Given this list of marker genes ZNF253, MED14, HIVEP3, ZNF620, SMURF2, TAF6, SUMO1, ZNF577, RAD50, SETD1B, RBL2, MLST8, ZNF625, SOX2, RFFL, ZNF324, TJP1, CNOT11, ARID3A, ZNF222, CDK6, DGCR8, RORA, ZNF479, USP7, G6PC1, MAPK3, MRE11, MED26, ZNF528, CDK13, COX7A2, ZNF496, H3-3A, NBN, TRPC3, ASH2L, ZNF140, PRKAG1, KLF4, MYBL2, ZIM2, PAX5, ZNF671, WRN, JUN, H19, NR4A2, THBS1, CDK5R1, ZNF439, ZNF233, TCF7, FOXP3, NFYA, KCTD15, TCF7L2, SCMH1, CDC27, PIN1 (NCBI Gene Id 5300), GATA3, APOE, PSMD11, ZNF875 (NCBI Gene Id 3102), PIDD1, BBC3, PSMD7, MED25, CDK5, MED20, RORB, ZNF614, ZNF429, ZFP69, ZNF77, ING2, H2BC1, ZNF746, PSMB7, SMARCC2, SREBF1, BCL6, PHC2, IQSEC3, COX4I2, ZNF621, ZNF860, CNOT2, ZNF703, H3C15 (NCBI Gene Id 449003), TAF4, ZNF471, ZNF665, BRD7, ZNF840P, ZNF561, MIR132, ZKSCAN8, ZKSCAN7, MTOR, SKP2, TXNRD1 (NCBI Gene Id 7296), ZNF767P, PSMB4, ZNF485, AURKB, KRABD4, SMARCD3, ZNF589, MAML2, GLI2, TGIF1, ZNF692, MIR302B, PPP2R5C, NR2E1, TFAP2B, ZNF670, SP1, NLRC4, ZNF92, COL1A2, SMARCD2, KMT2A, ZNF544, RETN, PF4, CCNK, POLR2H, CHM, CTSK, ZNF717, MAP2K6, PSMC6, ZNF394, PIP4P1, PPM1D, RMI2, SUPT4H1, ZNF221, SP7, CTDP1, TAF10, NR2F6, ZKSCAN4, RPA3, SMARCA4, ZNF555, FOS, YWHAZ, ZNF702P, NR5A2, PSMC1, HNF4G, BRPF3, CCNT2, E2F4, EHMT1, ZNF569, BRCA1, MOV10, DAXX, TAF7L, ZFP90, ZNF529, PCGF2, NR1I2, NCOR1, RAD17, EP300, RAD1, PTEN, POLR2G, UBE2E1, CLDN5, PSMC5, WWTR1, AGO1, TP53AIP1, MT-CO2, ZNF75A, CCNH, PHF20, MIR17, ZNF549, ZNF677, BLK, DDIT3, RPA2, COX7A2L, NR4A1, PSMD6, SPI1, PSMA6, ERCC2, COX6A1, ZFP30 (ZFP30 zinc finger protein), RBBP7, ZNF667, ZNF585B, RBFOX1, WWP1 (NCBI Gene Id 81891), ZNF714, ZNF793, ZNF18, KMT2D, ZFP2, COX6C, CHEK2, ZNF721, ZNF792, ITGA5, CTNNB1, CTLA4, PTPN4, KRABD5, ZNF764, SGK1, H2AC4 (H2A clustered histone 4), NOTCH1, RXRG, SKI, ZNF302, ZNF552, NR3C1 (nuclear receptor subfamily 3 group C member 1), COX5B (cytochrome c oxidase subunit 5B), RARG, PRKAA2, USP9X, ZNF704, TAL1, ZNF235, TFAP2E, SLC2A3, ZNF268, ZNF706, DDIT4, MAPKAPK5, ZNF510, KAT5, AKT3, MED4, IGFBP1, ZNF202, ANAPC5, YWHAG, ZNF100, ZNF334, RGCC, COX8C, SOX9, NELFCD, RBBP4, MIR675, SPP1, PINK1, PCGF5, YWHAH (tyrosine 3-monooxygenase/tryptophan 5-monooxygenase activation protein eta), PRKACA, ZNF615, DLX5, VDR, ZNF506, ZNF224, H2BC11, COX8A, BGLAP, PPP1R13B, TTC5, MET, BRD1, TP73, ZNF517, RNF111, SKIL, PDPK1, CDC16, ZNF20, XPO1, PRDX1, ZNF317, ZNF718, COXFA4, PSMD13, PIP4K2C, COX7A1, STUB1, RXRB, ARID2, TNFRSF10D (TNF receptor superfamily member 10d), ADRM1, NRBP1, TNFRSF10A, ZNF331, UBE2C, ZNF738, HDAC2, ZNF443, ZNF71, DLX6, ZNF425, KRABD3, TGIF2, ZNF556, FKBP5, CAV1, GPRIN1, TAF8, YWHAE, SNW1, ANAPC4, ZNF169, BMP2, RING1, PSMD1, PLAGL1, RFC4 (replication factor C subunit 4), ZNF595, ZNF41, KAT6A, ABCA6, ZNF266, ZNF282, ZNF493, PRKAB2, ZNF662, SCO2, SMAD1, TGFB1, ZNF184, SOD2, ZNF727, H2BC3, LAMTOR4, ZNF446, TP53BP2, ZNF696, SRF, RFC2, LDB1, H2AZ2, MYC, ZIM3, TAF4B, ZNF697, FOXO1, SRC, MAML1, MBD3, ZNF772, CPAP, HSPD1, ZNF606, TAF1, CAT, NR3C2, GCK, ZNF416, GPS2, IFNG, ZNF33B, DPY30, ZNF180 (NCBI Gene Id 7733), FZR1, E2F7, ZNF154, FANCC, MIR20A, ZIK1, ZNF135, ZNF468, H2AC18, TEAD4, MED30, LEF1, H2AJ, ZNF554, ZNF682, TAF9B, ZSCAN25, L3MBTL2, BLM, POLR2C, PSMC4 (proteasome 26S subunit, ATPase 4), ZNF300 (NCBI Gene Id 91975), ZNF343, CTSL, CHEK1, CNOT7, SMARCB1, NR6A1, ZNF160, FOXO6, ZNF548, HDAC11, GAD1 (glutamate decarboxylase 1), COX6A2, ZNF417, ZNF10 (zinc finger protein 10), CDC7, ZNF565, MEN1, ZNF263, THRA, POLR2D, ZNF442, ZNF691, PRDM1, ZNF790, TRIM63, ZNF157, BID, COL1A1, CTSV, OCLN, ZNF114, HDAC4, miR-224, ZNF546, ZNF28, MDM2, ZFP69B, POU4F2, TXN, MED8, KRAS, ZNF483, TCF12, GTF2F2, ZNF587, WWOX, RARA, CDK2, PPARA, TXNIP, ZNF773, ZNF45, ZNF521, ABL1, YY1, ZNF23, MED23, UBE2S, ZNF658, NDRG1, ZNF311 (zinc finger protein 311), ELOA2, ZNF613, CNOT4, CAMK2A, POLR2K, THRB (thyroid hormone receptor beta), MYB, CCNB1, YAP1, ZNF799, ZFHX3, ZNF707, SMAD2, MOBP (NCBI Gene Id 4336), ZNF273, ZNF133, ZNF675, POU4F1, H2BC12L, ZNF710, TBP, H2BC21, ZNF530, TMEM219, CR1, UBE2I, CNOT8, H2BC9, CASP1, ZNF713, ZNF12, PRMT1, PRDX2, TSC2, ZNF678, TFAP2D, CREB1, CRADD, GLS (glutaminase), TAF11, ATXN3, CRH, SST, RYBP, POMC, REST (RE1 silencing transcription factor), CGA, ZNF660, SATB2, ESR1, MED15, ZKSCAN5, ZNF248, SMARCD1, ITGA2B, PSMD14, GATA1, ZNF655, ZNF234, FOXO4, PSMB1, ZNF99, CDK7 (NCBI Gene Id 116024), CDK9 (NCBI Gene Id 1025), ZNF175, TCEA1, CCNE2, ZFP37, POLR2L, CBX2, NR1H3, ZKSCAN1, ZNF37A, DEK, HIPK1, PPP1R13L, TNRC6B, MED17, IL2, ZNF480, TP53I3, COX7C, ZNF195, FOXG1, CDC25C, RAD9A, BDNF, ZNF460, RPA1, H2BC26, SIN3A, EGFR, YWHAQ, CDK12, BIRC5, COX5A, ZNF227, ZNF735, CSNK2A2, RFC3, ZNF337, ZNF490 (NCBI Gene Id 57474), MMP13, ANAPC11, MAPK11, LAMTOR5, PCK1, PRMT5 (protein arginine methyltransferase 5), MT-CO3, MAF, ZNF101, RBL1 (RB transcriptional corepressor like 1), MED13, CDK8, TP53RK, ZNF285, MSTN, PRMT6, ZNF705A, COX4I1, ZNF684, FASLG, E2F8, ELF2, ZNF274, ZNF430, ZNF774, CCNG2, ZNF649, ITGBL1, ZNF445, ZNF616, L3MBTL1, CGB3, DLL1, ZNF676, PIP4K2A, CCNG1, H2BC14, RSPO3, MGA, PTPN11, ZNF557, ZFP1, H2AC7, PHC1, MIR18A, GLS2, CSF2, CNOT10, ZNF431, HDAC5 (histone deacetylase 5), ZNF514, ZNF347, LMO2, PSMC3, CBX8, RRAGB, NFATC2, PSMD8, ZNF225, NELFB, PRELID1, FAS, GTF2H2, OPRK1, RUNX1, H2BC13, SETD1A, PLXNA4, ZNF705G (NCBI Gene Id 649563), MTA2, RBBP5, NKX2-5, KCNIP3, ZNF658B, AKT2, H2BC17, NELFA, HDAC1, TFAP2A, CNOT6, ZNF30, ZNF626, TRIM28, ZNF770, CNOT3, ZNF383, ZNF583, GSR (NCBI Gene Id 2936), ZNF562, SIRT3, RMI1, FOXO3, NUAK1, ZNF747, MED10, ZNF415, ZNF473, MAMLD1, AUTS2, NFE2, ZNF230, NAMPT, PSMA7, SOCS4, GRIN2A (NCBI Gene Id 2903), ZNF570, BTG2, NR2C2, AURKA, MECP2 (methyl-CpG binding protein 2), AGO3, PPM1A, IL3, ZNF567, TAF12 (TATA-box binding protein associated factor 12), ATF2, SESN3, NOC2L, BMAL1, ZNF705EP, STK11, CCNE1, ZNF584, RABGGTB, TFDP1, PGR, CCND1, ZNF26, COX7B, ZNF732 (zinc finger protein 732), ZNF267, ZNF730 (NCBI Gene Id 100129543), IL6, ZNF418, RFC5, H3C1, TBL1XR1, ATAD2, SSRP1, CAMK4, NRBF2, SESN2, ZNF500, ZNF782, LBR, OPRM1, ZNF669, FANCD2, ZNF155, STEAP3, PSMA1, H2BC5, KCTD1, TP53, E2F6, SFN, PRKAB1, MED24, ZNF211, ZNF664, HES1, TFDP2, ZNF607, RBBP8, SEM1, TOP3A, TRIAP1, E2F1, CCND3, AGO2, HNF4A (hepatocyte nuclear factor 4 alpha), KIT, CHD3, NR5A1, ZNF571, ARID1A, KMT2C, MAGED1, PPP2R1A, MT-CO1, PCNA, ZNF619, EZH2, RHEB, HEY2, GPX2, ZNF519, NR0B1, ZNF777, SMYD2, ZNF551, BANP, GTF2H4, SOCS3, ZNF681, ELL, MIR26A2, CCN2, ZNF791, PPP2CB, EPC1, NR2F1, ZNF215, ZNF785, GATA2, TWIST1, HIGD1C (NCBI Gene Id 613227), NEDD4L, PIP4K2B, ZNF839, PSMA3, NR1D1, PSMB2, H4C1 (NCBI Gene Id 8359), AGRP, GPI, GAMT, ERBB2, PPP2R1B, CBX3, PPARGC1A, ESRRG, POLR2B, RBM14, PRDX5, ARNT2, PRDM7, INS, PARP1 (NCBI Gene Id 142), CDK1, ZNF688, HTT, LAMTOR2, PMAIP1, PML, WDR5, TP53INP1, ZNF573, BRIP1, ZNF749, ZNF226, EXO1, MAPK14, NPM1, ATR, BCL2L14, ZNF354B, ZNF250, CDK4, GATA4, ZNF208, ZNF257, PSMA5, COX6B2, ZNF627, RUNX3, RORC, MED1, CASP10, PHC3, CASP6, YES1, PERP (p53 apoptosis effector related to PMP22), GPAM, ZNF550, MDC1, TAF13, SETD9, GTF2H3, LAMTOR3, GRIA2, PPARD, ZNF33A, ZNF34, ZNF700, ZNF43, ZNF223, HAND2, NR2C1, PPP2CA, CEBPB, ZNF320, HIPK2, MIR24-1, SMAD3, ZNF333, AR, ITCH, PRKCB, ZNF680, RAD51, GADD45A, RARB, MAX, CITED4, ZNF736, ZNF420, TWIST2, ZNF740, BRD2 (bromodomain containing 2), ZNF436, H2AB1, NR0B2, PRKCQ (protein kinase C theta), MYL9, TNKS1BP1, CSNK2B, TSC1 (NCBI Gene Id 7248), RRM2, SMAD6 (SMAD family member 6), RELA, GSK3B, ZNF74, SUZ12, CALM1, KDM5B, ZNF124, CCNA1, YEATS4, ZSCAN32, POLR2E (NCBI Gene Id 5434), ZNF709, TGFA, MDM4, SUPT16H, H2BC15, AGO4, CAMK2B, LMO1, MED16, RET, MSX2, NR1I3, PLK2, COX6B1, RAD51D, TNFRSF10B, KAT2B, TNRC6C, CCND2, ZNF484, ZNF324B (zinc finger protein 324B), HDAC3, G6PD, PLK3, SUPT5H, MEF2C, ELOB, RRAGA, PRKAG2, GATAD2A, KAT2A, ZNF79, ZNF724, ZNF382 (NCBI Gene Id 84911), DNA2, ZNF559, ZNF2, POLR2I, GTF2H1, TNFRSF10C, PMS2, ZNF771, FURIN, NOP2, JMY, GRIN2B, HUS1, ZNF17, ZNF547, NR1H2, PRKAG3, SIRT1, ZNF679, NR1H4, SMAD7, GAD2, RBX1, CITED1, STAT1, TCF3, ZNF761 (zinc finger protein 761), BRPF1, ZNF214, RPS27A, ZNF354C, SMARCC1, ELOA, TBL1X, POLR2J, ESR2, ZNF200, ACTL6A, ZNF75D, H2AC14, ZNF441, ZNF213 (zinc finger protein 213), TEAD3, NOTCH3, TAF9, IRAK1, ZFP14, MIR24-2, MEAF6, KMT2B, NPAS4, FANCI, MIR215, ZNF141, UBE2D3, ERCC3, CBX6, CNOT6L, TAF2 (TATA-box binding protein associated factor 2), UBB, NPPA, ZNF70, DYRK2, CNOT9, TBX5, MIR26A1, ZNF585A, ZNF398, UCMA, NOTCH2, DDB2, CDC23, CBX4, USP2, ANAPC15, PSMD3, TPX2, ZNF304, RRM2B, CDKN1A, ZNF641, RRAGC, JAG1, NPY, ZNF804B, ZNF433, TOPBP1, ZNF701, ZNF729, NELFE, ZNF287, TP63, UBA52, ZNF256, BMI1, ZNF586, ZFP28, ZNF599, ARID1B, MED6, TNFRSF18, MLH1, MED27, RB1, ZNF582, MAML3 (mastermind like transcriptional coactivator 3), POLR2F, PRR5, AKT1, EED, MED12 (mediator complex subunit 12), ZNF786, TAF5, PTPN1, TCF7L1, ZNF492, TAF7, SYT10 (NCBI Gene Id 341359), PITX2 (NCBI Gene Id 5308), CARM1, UXT, NR1D2, PBRM1, NFYC, GP1BA, RUNX2, PSMB3, ZNF264, ELOC, ZNF25, ZFPM1, ZNF726, ZNF563, ANAPC2, ZNF566, VENTX (NCBI Gene Id 27287), CBFB, NKX3-2, GTF2H5, PPARGC1B, ZNF189 (zinc finger protein 189), TAF3, EHMT2, ZNF568, CAMK2G, CCNC, ZNF611, ZNF776, ING5, PVALB, MED7, RNF2, H2AX, YWHAB, ZNF286A, CCNA2, GLI3, SIN3B, ZNF454, NFKB1, H2AC20, KMT5A, ZNF597, NCOR2, ZNF624, BTG1, ZNF432, RICTOR, ZNF668, LIFR, ZNF14, ZNF75CP, ZNF350, ZNF540, CDKN1B, ZNF385A, ACTL6B, PPARG, SLC38A9, PCGF6, ZNF610, CREBBP (NCBI Gene Id 1387, CREB binding protein), HDAC6, UBC, NFYB, ZNF711, ZNF596, MNAT1, ATM, ESRRB, PCBP4, SMARCA2, ZNF689, CSF1R, ANAPC7, ANAPC16, IHH, APAF1, GTF2F1, ZNF699, MAPKAP1, PSMA4, RPTOR, CYCS, ZNF737, PSMD2, ZNF716, H2BC4, MAPK1, NOTCH4, ZNF254, NR4A3 (nuclear receptor subfamily 4 group A member 3), BNIP3L, RXRA, ZNF419, ZNF560, ZNF138, HDAC8, ZNF470, ZNF778, LAMTOR1, ANAPC1, TEAD1, CASP2, TFAP2C, TAF1L, CNOT1, FBXO32, PSMB6, ZNF558, PSMD12, E2F5, RHNO1, ZNF440, H2AC6, CBX5, ESRRA, ZNF112, RBPJ, H2BC12, MIR106A, IGFBP3, PSMC2, ATRIP, RBFOX3, ZNF726P1, AIFM2, ZNF705D, SESN1, UBE2D1, RAD9B, VEGFA (NCBI Gene Id 7422), ZNF136, ZNF19, MSH2, TAF15, ZNF461, SERPINB13, MIR378, CITED2, NR2E3, TIGAR, ZNF3, HDAC7, CDKN2B, IL2RA, ZNF197, AXIN1, ZNF205, CCNT1, CDC26, HDAC10, ZNF354A, ZNF600, BARD1, ZNF426 (zinc finger protein 426), RNF34, ZNF775 (NCBI Gene Id 285971), TNRC6A, JUNB, BCL2L11, CAMK2D, HEY1, ARNT, ITGA4, LGALS3, PSMB5, HDAC9, CHD4, BAX, RRAGD, CUL1, ZNF486, ITGAL, NR2C2AP, SMARCE1, SKP1, PSMA2, YBX1, TRIM33, ATP1B4, RABGGTA, SERPINE1, YAF2, POLR2A, ZNF543, ANAPC10, PRKAA1, CDKN2A, SMURF1, ELF1, MIR137, CSNK2A1, GEM (GTP binding protein overexpressed in skeletal muscle), MED31, ZNF564, ZNF708, PRELID3A, TEAD2, GATAD2B, ZKSCAN3, ZNF212, KCTD6, MIR27A, ZNF750, ZNF605, SMAD4, here is a description of the gene set: Reactome Pathway: Generic Transcription Pathway <b>OVERVIEW OF TRANSCRIPTION REGULATION:</b> <br><br>Detailed studies of gene transcription regulation in a wide variety of eukaryotic systems has revealed the general principles and mechanisms by which cell- or tissue-specific regulation of differential gene transcription is mediated. Of the three major classes of DNA polymerase involved in eukaryotic gene transcription, Polymerase II generally regulates protein-encoding genes. Figure 1 shows a diagram of the various components involved in cell-specific regulation of Pol-II gene transcription. <br><br>Core Promoter: Pol II-regulated genes typically have a Core Promoter where Pol II and a variety of general factors bind to specific DNA motifs: <br> i: the TATA box (TATA DNA sequence), which is bound by the "TATA-binding protein" (TBP).<br> ii: the Initiator motif (INR), where Pol II and certain other core factors bind, is present in many Pol II-regulated genes.<br> iii: the Downstream Promoter Element (DPE), which is present in a subset of Pol II genes, and where additional core factors bind. <br>The core promoter binding factors are generally ubiquitously expressed, although there are exceptions to this.<br><br>Proximal Promoter: immediately upstream (5') of the core promoter, Pol II target genes often have a Proximal Promoter region that spans up to 500 base pairs (b.p.), or even to 1000 b.p.. This region contains a number of functional DNA binding sites for a specific set of transcription activator (TA) and transcription repressor (TR) proteins. These TA and TR factors are generally cell- or tissue-specific in expression, rather than ubiquitous, so that the presence of their cognate binding sites in the proximal promoter region programs cell- or tissue-specific expression of the target gene, perhaps in conjunction with TA and TR complexes bound in distal enhancer regions. <br><br>Distal Enhancer(s): many or most Pol II regulated genes in higher eukaryotes have one or more distal Enhancer regions which are essential for proper regulation of the gene, often in a cell or tissue-specific pattern. Like the proximal promoter region, each of the distal enhancer regions typically contain a cluster of binding sites for specific TA and/or TR DNA-binding factors, rather than just a single site. <br><br> Enhancers generally have three defining characteristics:<br> i: They can be located very long distances from the promoter of the target gene they regulate, sometimes as far as 100 Kb, or more.<br> ii: They can be either upstream (5') or downstream (3') of the target gene, including within introns of that gene.<br> iii: They can function in either orientation in the DNA.<br><br>Combinatorial mechanisms of transcription regulation: The specific combination of TA and TR binding sites within the proximal promoter and/or distal enhancer(s) provides a "combinatorial transcription code" that mediates cell- or tissue-specific expression of the associated target gene. Each promoter or enhancer region mediates expression in a specific subset of the overall expression pattern. In at least some cases, each enhancer region functions completely independently of the others, so that the overall expression pattern is a linear combination of the expression patterns of each of the enhancer modules.<br><br>Co-Activator and Co-Repressor Complexes: DNA-bound TA and TR proteins typically recruit the assembly of specific Co-Activator (Co-A) and Co-Repressor (Co-R) Complexes, respectively, which are essential for regulating target gene transcription. Both Co-A's and Co-R's are multi-protein complexes that contain several specific protein components.<br><br>Co-Activator complexes generally contain at lease one component protein that has Histone Acetyl Transferase (HAT) enzymatic activity. This functions to acetylate Histones and/or other chromatin-associated factors, which typically increases that transcription activation of the target gene. By contrast, Co-Repressor complexes generally contain at lease one component protein that has Histone De-Acetylase (HDAC) enzymatic activity. This functions to de-acetylate Histones and/or other chromatin-associated factors. This typically increases the transcription repression of the target gene.<br><br>Adaptor (Mediator) complexes: In addition to the co-activator complexes that assemble on particular cell-specific TA factors, - there are at least two additional transcriptional co-activator complexes common to most cells. One of these is the Mediator complex, which functions as an "adaptor" complex that bridges between the tissue-specific co-activator complexes assembled in the proximal promoter (or distal enhancers). The human Mediator complex has been shown to contain at least 19 protein distinct components. Different combinations of these co-activator proteins are also found to be components of specific transcription Co-Activator complexes, such as the DRIP, TRAP and ARC complexes described below. <br><br>TBP/TAF complex: Another large Co-A complex is the "TBP-associated factors" (TAFs) that assemble on TBP (TATA-Binding Protein), which is bound to the TATA box present in many promoters. There are at least 23 human TAF proteins that have been identified. Many of these are ubiquitously expressed, but TAFs can also be expressed in a cell or tissue-specific pattern. <br><br> <b> Specific Coactivator Complexes for DNA-binding Transcription Factors.</b> <br><br>A number of specific co-activator complexes for DNA-binding transcription factors have been identified, including DRIP, TRAP, and ARC. The DRIP co-activator complex was originally identified and named as a specific complex associated with the Vitamin D Receptor member of the nuclear receptor family of transcription factors. Similarly, the TRAP co-activator complex was originally identified as a complex that associates with the thyroid receptor. It was later determined that all of the components of the DRIP complex are also present in the TRAP complex, and the ARC complex (discussed further below). For example, the DRIP205 and TRAP220 proteins were show to be identical, as were specific pairs of the other components of these complexes.<br><br>In addition, these various transcription co-activator proteins identified in mammalian cells were found to be the orthologues or homologues of the Mediator ("adaptor") complex proteins. The Mediator proteins were originally identified in yeast by Kornberg and colleagues, as complexes associated with DNA polymerase. In higher organisms, Adapter complexes bridge between the basal transcription factors (including Pol II) and tissue-specific transcription factors (TFs) bound to sites within upstream Proximal Promoter regions or distal Enhancer regions (Figure 1). However, many of the Mediator homologues can also be found in complexes associated with specific transcription factors in higher organisms. A unified nomenclature system for these adapter / co-activator proteins now labels them Mediator 1 through Mediator 31. For example, the DRIP205 / TRAP220 proteins are now identified as Mediator 1, based on homology with yeast Mediator 1.<br><br> <b>Example Pathway: Specific Regulation of Target Genes During Notch Signaling:</b> <br><br>One well-studied example of cell-specific regulation of gene transcription is selective regulation of target genes during Notch signaling. Notch signaling was first identified in Drosophila, where it has been studied in detail at the genetic, molecular, biochemical and cellular levels. In Drosophila, Notch signaling to the nucleus is thought always to be mediated by one specific DNA binding transcription factor, Suppressor of Hairless. In mammals, the homologous genes are called CBF1 (or RBPJkappa), while in worms they are called Lag-1, so that the acronym "CSL" has been given to this conserved transcription factor family. There are at least two human CSL homologues, which are now named RBPJ and RBPJL. <br><br>In Drosophila, Su(H) is known to be bifunctional, in that it represses target gene transcription in the absence of Notch signaling, but activates target genes during Notch signaling. At least some of the mammalian CSL homologues are believed also to be bifunctional, and to mediate target gene repression in the absence of Notch signaling, and activation in the presence of Notch signaling.<br><br>Notch Co-Activator and Co-Repressor complexes: This repression is mediated by at least one specific co-repressor complexes (Co-R) bound to CSL in the absence of Notch signaling. In Drosophila, this co-repressor complex consists of at least three distinct co-repressor proteins: Hairless, Groucho, and dCtBP (Drosophila C-terminal Binding Protein). Hairless has been show to bind directly to Su(H), and Groucho and dCtBP have been shown to bind directly to Hairless. All three of the co-repressor proteins have been shown to be necessary for proper gene regulation during Notch signaling in vivo.<br><br>In mammals, the same general pathway and mechanisms are observed, where CSL proteins are bifunctional DNA binding transcription factors (TFs), that bind to Co-Repressor complexes to mediate repression in the absence of Notch signaling, and bind to Co-Activator complexes to mediate activation in the presence of Notch signaling. However, in mammals, there may be multiple co-repressor complexes, rather than the single Hairless co-repressor complex that has been observed in Drosophila. <br><br>During Notch signaling in all systems, the Notch transmembrane receptor is cleaved and the Notch intracellular domain (NICD) translocates to the nucleus, where it there functions as a specific transcription co-activator for CSL proteins. In the nucleus, NICD replaces the Co-R complex bound to CSL, thus resulting in de-repression of Notch target genes in the nucleus (Figure 2). Once bound to CSL, NICD and CSL proteins recruit an additional co-activator protein, Mastermind, to form a CSL-NICD-Mam ternary co-activator (Co-A) complex. This Co-R complex was initially thought to be sufficient to mediate activation of at least some Notch target genes. However, there now is evidence that still other co-activators and additional DNA-binding transcription factors are required in at least some contexts. <br><br>Thus, CSL is a good example of a bifunctional DNA-binding transcription factor that mediates repression of specific targets genes in one context, but activation of the same targets in another context. This bifunctionality is mediated by the association of specific Co-Repressor complexes vs. specific Co-Activator complexes in different contexts, namely in the absence or presence of Notch signaling. species: Homo sapiens part of: RNA Polymerase II Transcription